Given this list of marker genes EP300, SLC32A1 (solute carrier family 32 member 1), IGF2, GPC4, CDKN1C, GPC3, KCNQ1, KCNQ1OT1, here is a description of the gene set: species: Homo sapiens Permanent indentation on the posteromedial aspect of the helix that may be sharply or indistinctly delineated. Human Gene Set: HP_POSTERIOR_HELIX_PIT Posterior helix pit